Given this list of marker genes DYNLT3, PPFIA1, SSB, HTATSF1, KANK2, CENPB, ANKRD11, GAB2, SYCP3, TP53INP2, RAB13, CCND2, XAF1, PKP4, KCTD10, BMI1, APC, DCAF5, SH3BGRL, MAP2K7, PALLD, CCNG1, DYNLL2, BBIP1, ZEB1, MFF, PHLDB2, INPP1, COA5, SAMD4A, C1orf216, FBXO32, KIF1C, RGS20 (NCBI Gene Id 8601), EIF3E (NCBI Gene Id 3646), EIF2A, ZBTB12, VCPIP1, SEPTIN7, CCDC34, CYB5R3, RFLNB, HNRNPA3, NAA50, DDR2, DKC1, RBIS, KIF5B, MAP1B, here is a description of the gene set: Human Gene Set: MILI_PSEUDOPODIA RNA localization is important for the establishment and maintenance of polarity in multiple cell types. Localized RNAs are usually transported along microtubules or actin filaments and become anchored at their destination to some underlying subcellular structure. Retention commonly involves actin or actin-associated proteins, although cytokeratin filaments and dynein anchor certain RNAs. RNA localization is important for diverse processes ranging from cell fate determination to synaptic plasticity; however, so far there have been few comprehensive studies of localized RNAs in mammalian cells. Here we have addressed this issue, focusing on migrating fibroblasts that polarize to form a leading edge and a tail in a process that involves asymmetric distribution of RNAs. We used a fractionation scheme combined with microarrays to identify, on a genome-wide scale, RNAs that localize in protruding pseudopodia of mouse fibroblasts in response to migratory stimuli. We find that a diverse group of RNAs accumulates in such pseudopodial protrusions. Through their 3' untranslated regions these transcripts are anchored in granules concentrated at the plus ends of detyrosinated microtubules. RNAs in the granules associate with the adenomatous polyposis coli (APC) tumour suppressor and the fragile X mental retardation protein (FMRP). APC is required for the accumulation of transcripts in protrusions. Our results suggest a new type of RNA anchoring mechanism as well as a new, unanticipated function for APC in localizing RNAs. from publication Mili S, Moissoglu K, Macara IG (PMID 18451862) Transcripts significantly enriched in pseudopodia of NIH/3T3 cells (fibroblast) in response to both chemotactic (lysophosphatidic acid, LPA) and haptotactic (fibronectin, FN1 [GeneID=2335) migratory stimuli. species: Mus musculus